The following is a description of a gene set: With increasing age, the ability of the immune system to protect against recurring infections or to control chronic infections erodes. The objective of the current study was to identify gene expression signatures in elderly CD4 T cell responses Human Gene Set: GSE36476_CTRL_VS_TSST_ACT_40H_MEMORY_CD4_TCELL_OLD_UP studied in species Homo sapiens Genes up-regulated in comparison of untreated CD4 memory T cells from old donors versus those treated with TSST at 40 h. from publication Yu M, Li G, Lee WW, Yuan M, Cui D, Weyand CM, Goronzy JJ (PMID 22434910), and this is the list of marker genes: EFCAB6, PLCD1 (NCBI Gene Id 5333), DPEP2, SEMA3G, CHD1, CIRBP, GCNT3, BAIAP2L2, DNAJB1, TXNIP, DYRK2, KCNH2, NLRP3, FYB1, FPR1, DNAJB9, ANXA1, ADD3, YPEL5, PLIN1, KAT6B, RIPOR2, NPY2R, NR4A2, SIK1, DAZAP2, ATF7IP2, PTCH1, MYBL1, USPL1, LRIG2, FCGRT, CLSTN1, NCOA1, RBM48, FAM204A, GRIN1, ZFP36L2, RAD52, ATP6V0A1, RPL34, GATA3, EPHA4, IQSEC1, NKTR, IL17RA, SORL1, RHPN1-AS1, DUSP1, MCF2L, ARL4A, MED13L, HSF2BP, TNNC2, DTX4, CLDN6, CADM1, ARHGEF18, ZBTB43, LARS1, PDZRN4, RPL10P17, CR2, KIAA1614, ATMIN, PBXIP1, ZBTB5, RASGRP2, CYP4F12, ZBTB20, SLC16A10, TBC1D30, ARL4C, DPF3, SLC8A1, THBS2, LONP2, SLC7A2, APBB1IP, RAP1GAP2, DCAF4, ITGB2, MOAP1 (modulator of apoptosis 1), RHBDF1, ZBP1, XYLT1, MYH11, WIPF2, TSC22D3, RLF, ZNF395, DGKD, IRS2 (NCBI Gene Id 90066), ASIC1, UBE2G2, CNTN2, PBX3-DT, MROH7, RPL23AP53, IL11RA, NR3C2, IFITM1, TRIB2, MPPED1, TAS2R13, CBFA2T3, IPCEF1, HRG, ITGB1, WNT10B (NCBI Gene Id 82499), VCPIP1, GABRB2, LDB3, MARCHF8, CDH17, AQP3, HBQ1, LINC00667, TENT5C, ZNF331, TRAM1, PDE1A, MC1R, USP19, EEF1D, PTGER4, ZNF529, STAT2, ACTR5, MYEF2, RALGAPA1, ZC3HAV1, SUN2, PHF24, ERC2-IT1, OLFML3, MAGEA5P, OSER1, ELF2, FAM8A1, KCNK15-AS1, RORA, TOB1, LIPT1, PTPRE, AMT, SGK1, C11orf21, FOSL2, ADGRV1, FABP7, USP36, TSPYL1, GPR88, USP3, SLC2A3, PLCL2, PFN2, MATN1, ACACB, JOSD1, PIK3IP1, GNAQ, PXDN, WNT7A, MAS1, RPS27, SLC17A9, MYCN, CHI3L2, ARGLU1, MNT, PDZD8, CPS1, BTN3A1, TMX4, PREX2, MXI1, PDK1, AFF1, TTC17 (tetratricopeptide repeat domain 17), CD69, P2RX1 (NCBI Gene Id 5023), PZP, FOS, PPP1CB, TNFRSF10B, JUN, ATP6V1G1, HTR1E, LILRA6, KLF2, TLR3, ATXN7, PTP4A1, THUMPD1, PPARGC1A, CCL16